The following is a description of a gene set: Genes having at least one occurrence of the motif NCMGGAWGYN in the regions spanning 4 kb centered on their transcription starting sites. This matches the ETS1 transcription factor binding site V$CETS1P54_01 (v7.4 TRANSFAC). Human Gene Set: CETS1P54_01 studied in species Homo sapiens, and this is the list of marker genes: CCDC174, HCST, DNMT1, BLNK, RNF31, ZNF585B, TCF7, TMEM71, APOLD1, U2AF2, RPS18, DDOST, NMNAT1, GTF3C1, CHD2, HNRNPD, TYMP, DPP8, XAB2, PPIG, TRPC4AP, ZDHHC5, LSM1, INTS3, BAG6, GSPT1, MMP1, LRRC41, CSGALNACT2, MED8 (NCBI Gene Id 115853), ACAD11, TFE3, TNF, KRTCAP2, MRPL3, NEDD8, PPME1, CELF1, PTRH2, HTR2C, CCP110, HOXC4, ZNF322, PRKAG2, AP1M1, STX19, RBMS2, TIGD6, LIN28A, SNRPB, CTCF, TSPAN31, HNRNPLL, AZI2, PSMD13, MTIF2, NIPBL, FOXN3, CHID1, ARF3, TRAPPC1, PYROXD1, PSMD12, LYPLA2, TMUB2, PYM1, PIH1D2, MTMR2, RAP2C, PARS2, LINC03124, ZCRB1, PDZRN4, SEC24C, FBXO3, EIF5A, BCL2L1, ARL5B, SZT2 (NCBI Gene Id 79597), LRRC49, NFKBID, ZNF408, GABRA1, TBCC, FBXO28, MLEC, ERI2, MEF2C, CSNK2B, ZBTB11, APPL2, DDX39B, IL11RA, ERCC6, CPEB4, UFC1, PRKACB, DNAJA2, PAFAH1B2, STX11, PTPRN, TBC1D17, GNAI3 (NCBI Gene Id 2773), PLEKHH2 (pleckstrin homology, MyTH4 and FERM domain containing H2), RPL26, FGFR4, BAG4, ACP2, DLST, TOMM22 (NCBI Gene Id 56993), WRAP73, SIPA1, UGGT2 (UDP-glucose glycoprotein glucosyltransferase 2), ZNF175, CNTROB, BAZ2A, ZNF687, COX17, RWDD4, CEP164, FNTA, NOSIP, TRIM44, ZNF585A, THAP10, GMPR2, ZNF24, TEAD3, MKRN3, VMP1, WDR74, MON1B, STK10, DDX47, ZNF22, VPS52, REXO5, MTOR, OGG1, SYVN1, LZIC, ITM2C, RGS14, EPN1, MTPN, IL7R, SHC3, PPHLN1, CRADD, KANSL1, NKAPD1, RPLP2, CD3E, DCTN5, KAT5, SLC30A7, ZNF384, EXTL2, PPP4C, SPI1, ARHGAP1 (Rho GTPase activating protein 1), ACVR2A, TNFSF13, TOMM70, GDE1, ACTR2, SYT5, NASP, MAPKAPK2, ZKSCAN5, STK4, RPL6, NF1, DCUN1D3, TFCP2, TRAPPC11, UHMK1, ZC3H11A, UQCRH, UBA5, TRIM46, PNMA1, CTR9, PRKACA, CFAP57, DR1, CGGBP1, PSME2, LRP5, DPCD, NHSL2, PRPF19, ITGB3BP, EPHA2, GTSF1, GPN2, CAST, NRDC (NCBI Gene Id 4898), MCTS1, GGN, SHC1, RLIM, TNKS2, SPTY2D1, CALU, MRPL52, SPIB, LAG3, NR1H2, GCNT3, BTAF1, LINC01565, CHMP1B, ZNF35, CSF3, CAP1, SPRY2, ZNF70, HM13, HERC4, DMTF1, AKT1S1, ANAPC15, IPO7, UBE2F, FMR1, DNAJC1, NRAS, MUSK, POLL, GPANK1, INSIG2, RGL2, PRKAG1, BCDIN3D, STARD13, EBNA1BP2, KMT5A, TPGS1, ZNF184, CKS1B, PSMC2, EGFL7, ARRB2, B3GAT3, INO80B, TUBA1B, AP1B1, ATOH8, PIK3R4, HMG20A, SRSF6, EN1, PPIL1, STOML2, ARL4C (NCBI Gene Id 10123), ZNF768, ZNF22-AS1, SMAP2, FAM174A, PALB2, RRAS, LYRM1, BDKRB2, MPZL3, SIRT3